The following is a description of a gene set: studied in species Homo sapiens EGF-EGFR-PI3K-NFKB signaling pathway. Pathway ID: N00390. Pathway type: Reference. Pathway class: nt06214 PI3K signaling. Human Gene Set: KEGG_MEDICUS_REFERENCE_EGF_EGFR_PI3K_NFKB_SIGNALING_PATHWAY Pathway Definition from KEGG: EGF -> EGFR -> PI3K -> PIP3 -> AKT -> IKK -> NFKBIA -> NFKB, and this is the list of marker genes: PIK3CB, CHUK, EGFR, EGF, IKBKB, PIK3CD, PIK3CA, IKBKG, AKT1, AKT2, AKT3, RELA, NFKBIA, NFKB1